Given this list of marker genes HLA-B, HLA-DRA, HLA-E, HLA-G, HLA-A, HLA-F, HLA-DOA, HFE, HLA-DOB, B2M, HLA-C, HLA-DMB, HLA-DRB5, HLA-DRB4, here is a description of the gene set: Human Gene Set: MODULE_143 species: Homo sapiens Genes in the cancer module 143.